The following is a description of a gene set: from publication Hutcheson J, Scatizzi JC, Siddiqui AM, Haines GK 3rd, Wu T, Li QZ, Davis LS, Mohan C, Perlman H (PMID 18275831) studied in species Homo sapiens Gene expression profile studies have identified an interferon signature in whole blood or mononuclear cell samples from patients with systemic lupus erythematosus. This study was designed to determine whether specific lymphocyte and myeloid subsets freshly isolated from the blood of systemic lupus erythematosus patients demonstrated unique gene expression profiles compared to subsets isolated from healthy controls. Genes up-regulated in comparison of systemic lupus erythematosus CD4 T cells versus systemic lupus erythematosus B cells. Human Gene Set: GSE10325_LUPUS_CD4_TCELL_VS_LUPUS_BCELL_UP, and this is the list of marker genes: TIAM1, STAT5B, KLRB1, TRAV8-3, RIOX1, TRAC, ZNF204P, SOD1, GATA3, RAB33A, PIK3IP1, IL6ST, HSPA1L, GIMAP4, MAN1C1, DHRS3, SPOCK2, PRKCA, TBC1D4, LPIN2, CD3G, TRBC1, CD2, UXS1, TIMP1 (NCBI Gene Id 7076), CCSER2, LRIG1, LCP2, CERK, NDRG1, CTLA4, ADGRE1, RETREG1, ACTN1, IL11RA, TRMO, LEF1, TXK, PLAAT4, MAP7D1, RGS10, TSPAN14, EEIG1, B3GNT2, ABITRAM, TNFSF8, ATP2B4, PIM1, ADTRP, CDC25B, RBMS1, GALNT12, DOCK9, GMFG, NMRK1, TRADD, CD247, GOLGA7, MAL, PRKCH (NCBI Gene Id 79030), MAST4, IL32, ITK, DGKA, DPP4, SIRPG, BEX3, LDHB, CYB561, CPD, STAT4, AP3M2, TMEM43, LCK, CD3D, PLCL1, CAMK4, ULK2 (unc-51 like autophagy activating kinase 2), UBASH3A, KIF21B, ZMYM6, USP20, TRAT1, ZCCHC14, CYLD, RAPGEF6, MAF (NCBI Gene Id 4094), SEMA4C, OPTN, ATP6V0E2, STN1, SVIL, HDAC4, TATDN2, NOSIP, STX2, MT1X, ARL4C, PBXIP1, SEMA4D, FBXL8, PCSK5, ITM2A, RAB15, CISH, NELL2, SF3A1, AKT3, ANXA1 (NCBI Gene Id 301), ITM2B, CASK, NFRKB, AKTIP, LEPROTL1, GSTK1, DNAJB1, PXN, CD3E, RNF144A, SELPLG, CD28, IL7R, TRIM16, KIAA0513, ANKRD55, ACVR1, CD5, LRFN3, LIMA1, CD6, HECA, GIMAP5, INPP4B, FHIT, UBAP1, WWP1, PTPN4, TMEM30B, PLEKHB1, LDLRAP1, IPCEF1, BMAL1, CREBL2, MFNG, FYB1, LPAR6, RUNX1, GIMAP6, CLUAP1, PLK3, PRKCQ, GNAQ, MLLT3, HIVEP2, APBA2, MEOX1, TBC1D2B, FBLN5, FAM171A1, FHL1, EPHX2, KDSR, FYN, ICOS, ZAP70, UGP2, ATP1A1, MGAT4A (NCBI Gene Id 11320), CHST7, GPA33, ITPKB, ZNF764, TESPA1, BAG3, CDR2, MCUB, BCL11B, SIGIRR, UPP1, PTGER2, SERINC5, MAPKAPK3, TNFRSF4, PLCG1, SKAP1, TRDV2, DNMT1, PIK3R1, ITGA6, TCF7 (NCBI Gene Id 6932), CD4, SH2D2A, TNIK, ZBTB25, TNFRSF25, SLC8B1, HK1, ATP10A, GPR171